The following is a description of a gene set: from publication Cui A, Huang T, Li S, Ma A, Pérez JL, Sander C, Keskin DB, Wu CJ, Fraenkel E, Hacohen N (PMID 38057668) species: Mus musculus Cytokines mediate cell-cell communication in the immune system and represent important therapeutic targets. A myriad of studies have highlighted their central role in immune function, yet we lack a global view of the cellular responses of each immune cell type to each cytokine. To address this gap, the authors created the Immune Dictionary, a compendium of single-cell transcriptomic profiles of more than 17 immune cell types in response to each of 86 cytokines (>1,400 cytokine-cell type combinations) in mouse lymph nodes in vivo. A cytokine-centric view of the dictionary revealed that most cytokines induce highly cell-type-specific responses. For example, the inflammatory cytokine interleukin-1β induces distinct gene programmes in almost every cell type. A cell-type-centric view of the dictionary identified more than 66 cytokine-driven cellular polarization states across immune cell types, including previously uncharacterized states such as an interleukin-18-induced polyfunctional natural killer cell state. Mouse Gene Set: CUI_MAST_CELL_IFNA1_RESPONSE_UP Genes positively differentially expressed in cell type: Mast cell upon treatment with cytokine: IFN-α1 in mouse lymph nodes in vivo., and this is the list of marker genes: Herpud2, Ly6e, Helz2, Ppp1r13b, Rsad2, Slfn2, Oasl1, Ifit3b, Parp9, Usp18, Irf7, Triobp, Ifitm3, Isg15, Ifit3, Dync1h1, Mov10, Eif2ak2, Ifit1, Gbp7, Znfx1, Arl6ip1, Cmpk2, Parp12, Psme2, H2-D1, Lratd2, Oasl2, Sp100, Samhd1, Flii, Psmb10, H2-Q7, Parp14, Cd200r4, 9930111J21Rik2, Ifi207, Herc6, Stat2, Irf1, Vim, Psmb8, Selenow, Trim30d, Zup1, Ifih1, Ifi204, B2m, Tapbp, Zbp1, Iigp1, B4galt5 (UDP-Gal:betaGlcNAc beta 1,4-galactosyltransferase, polypeptide 5), Lamp2, Rtp4 (receptor transporter protein 4), Mndal, Trim30c, Grn, Ilrun, Tap1, Rnf114, Trafd1, Irgm1, Tor3a, H2-T23, Isg20, Trim30a (tripartite motif-containing 30A), H2-T22, Ly6a, Phf11b, Tmbim6, Cd47, Ifi47, Xaf1, Ddx60, Ifi208, Gbp2, Ifi209, Clic4 (NCBI Gene Id 29876), Sema4d, Oas1a, Lgals3bp, Etnk1, Rigi, Cxcl9, Gbp4, Usb1, Bst2, Epsti1, Mx1, Slfn5, H2-K1, Oas3, Sp140, Samd9l, Parp10, Slfn9, Irgm2, Ifit2, Aida, Rnf213, Clec2d, Stat1, Psme1, Cxcl10, Setdb2, Ifi203, Psmb9, Tspo, Ube2l6, Igtp, Rasa4